The following is a description of a gene set: from publication Chen H, Rubin E, Zhang H, Chung S, Jie CC, Garrett E, Biswal S, Sukumar S (PMID 15757903) The homeobox gene HOXA5 encodes a transcription factor that has been shown to play important roles in embryogenesis, hematopoiesis, and tumorigenesis. In order to decipher downstream signaling pathways of HOXA5, we utilized oligonucleotide microarray analysis to identify genes that are differentially expressed in HOXA5-induced cells compared with uninduced cells. Comparative analysis of gene expression changes after 9 h of HOXA5 induction in Hs578T breast cancer cells identified genes whose expression was modulated at least 2-fold. Ten of these genes were also up-regulated by at least 2-fold at 6 h post-induction. The expression of all of these genes was confirmed by semiquantitative reverse transcription-PCR. Among these genes, which are most likely to be direct targets of HOXA5, we initiated an investigation into the pleiotrophin gene by first cloning its promoter. Transient transfection assays indicated that HOXA5 can specifically activate the pleiotrophin promoter. Promoter deletion, chromatin immunoprecipitation assay, and gel-shift assays were performed to show that HOXA5 can directly bind to one binding site on the pleiotrophin promoter. These data strongly suggest that microarray analysis can successfully identify many potential direct downstream genes of HOXA5. Further functional analysis of these targets will allow us to better understand the diverse functions of HOXA5 in embryonic development and tumorigenesis. Genes down-regulated 9 h after induction of HoxA5 expression in a breast cancer cell line. Human Gene Set: CHEN_HOXA5_TARGETS_9HR_DN studied in species Homo sapiens, and this is the list of marker genes: GEMIN4, KDELR1, SLC29A1, AP1S1, EHD2, SYNE3 (NCBI Gene Id 79686), WNT5B, AKAP1, CKAP4, TRIM34, CBX6, LPCAT1, MYL9, FJX1, SKP2, SV2A, MARCKS, DDT, SERPINH1, FEN1, FZD2, TOMM22, GM2A, GLG1, H2AX, LOXL1, RTL8C, TMEM97, HMGB3, ST6GALNAC4, SYNGR2, COA3, PRR16, PLPP2, ANPEP, PCDHGC3, UBTF, INO80B, G6PC3, ANP32A, PAGR1, MAT2A